Given this list of marker genes KISS1R, KANK2, MKNK2, KANSL1, SGK2, TNKS, PLCXD2, TLE5, RAB3IL1, PPP1R3F, BCL11B, APC2, TLE6, GIPR, TJP3, NFIC (NCBI Gene Id 4782), AK1, COL16A1, IL12RB1, HOMER3, CACNA1A, CELF5, NUAK2, MRPL34, CRHR1, TMEM161A, FBXL18, HIPK4, NOP53, MT2A, ENSG00000267174, PLK5, SIGLEC1, ARHGEF10L, TFEB, MARK4, TPGS1 (tubulin polyglutamylase complex subunit 1), C1orf21-DT, LINC02559, PALM, HMG20B, KTN1, ARL5C (ADP ribosylation factor like GTPase 5C), ADGRG1, KANSL1-AS1, VAV1, TPM4, CYP4F26P, ADCK2 (aarF domain containing kinase 2), DUSP5-DT (DUSP5 divergent transcript), IGSF21, SEMA6B, SIRT6, ARHGAP45, KRT86, MFNG, GTF2IRD1, CD79B, CCDC159, ADORA2A, ERCC1, CYGB, KCNJ2-AS1, MYO5A, SYMPK, DAB2IP, LTBP3, KCNN1, YJU2B, PGLS, CERS4, TRIM45, ROM1, EML3, PLA2G6, BCR, RASGRP2, SAMD4B, here is a description of the gene set: from publication Yevshin I, Sharipov R, Kolmykov S, Kondrakhin Y, Kolpakov F (PMID 30445619) Genes containing one or more binding sites for (ZNF16) in their promoter regions (TSS -1000,+100 bp) as identified by GTRD version 20.06 ChIP-seq harmonization. Human Gene Set: ZNF16_TARGET_GENES species: Homo sapiens